Given this list of marker genes PSMD6, JAK1, PSMD7, IL6R, XIAP, SEM1, PSMB4, PSMD1, PSMA3, IL6ST, ARHGEF4, PSMB2, SRC, PSMD8, PSMC2, PSMB3, ACTB, CTNNB1, NFKB1, UBB, RPS27A, PSMD2, PSMD3, FARP2, PSMD11, UBC, PSMB6, IL6, PSMC3, PSMB1, STAT3, RELA, ACTC1, CTNND1 (catenin delta 1, NCBI Gene Id 82168), ACTA2, JAK2, CDC42, PSMB7, PSMA2 (NCBI Gene Id 5683), CDH1, PSMA5, PSMA1, JUP, VCL, CTSB, PSMC5, TYK2, PSMA7, UBA52, CDH11, HACE1, PSMC1, PSMA4, TIAM1, CTSL, PSMD13, BIRC2, CTSS, PSMA6, VAV2, CTNNA1, PSMD12 (proteasome 26S subunit, non-ATPase 12), CBLL1, RAC1, PSMC4, RNF19B, ACTA1, ADRM1, TRAF7, PSMD14, PSMC6, ACTG2, PSMB5 (proteasome 20S subunit beta 5), ACTG1, ELMO1, DOCK1, here is a description of the gene set: part of: Adherens junctions interactions Reactome Pathway: Activation of STAT3 by cadherin engagement studied in species Homo sapiens <p><b>The signal transducer and activator of transcription-3 (STAT3):</b></p><p>STAT3 is a latent cytoplasmic transcription factor, activated by receptor tyrosine kinases such as EGFR, or PDGFR, cytokine receptors such as the Interleukin-6 receptor family (IL6R or gp130 – also known as IL6ST), and non-receptor tyrosine kinases such as SRC. Activation entails phosphorylation of the critical tyrosine-705 residue (p-Y705) of STAT3 by the receptor itself or an associated Jak kinase, dimerization and translocation to the nucleus. The dimers subsequently bind specific DNA sequences to activate the transcription of specific genes involved in cell division and survival, while they downregulate the tumor suppressor p53, thus protecting tumor cells from apoptosis. Hyperactivation of STAT3 is present in a large number of cancers and has been reported to be required for tumour cell growth, survival, angiogenesis, metastasis and immune evasion, while a hyperactive form of Stat3 (Stat3C) is able to transform cultured cells.</p><p><b><u>Activation of Stat3 by cadherin engagement</u></b></p><p>Early results demonstrated that cell to cell contact, as occurs with confluence, or aggregation of cultured cells, leads to a dramatic increase in phosphorylation of STAT3 at the activating tyrosine-705 (p-Y705-STAT3), DNA binding and transcriptional activity, in both non-transformed mouse or rat fibroblasts or MCF-10A human breast cells, as well as in a series of four human breast cancer cell lines, and a number of human lung cancer cell lines.</p><p>It was later definitively demonstrated that STAT3 is activated by direct homophilic interactions of E-cadherin (CDH1) molecules of the opposing cells, even in the absence of direct cell to cell contact. This was shown by plating mouse epithelial HC11 cells onto surfaces coated with fragments encompassing the two outermost domains of CDH1. In fact, CDH1 engagement was shown to trigger a dramatic surge in total RAC1 and CDC42 protein levels and activity through inhibition of proteolytic degradation, and this was responsible for the STAT3 activation observed. It was further demonstrated that the increase in RAC1/Cdc42 activity leads to transcriptional upregulation of members of the IL6 family of cytokines through the transcription factor NFκB and activation of the common receptor, gp130 (IL6ST), leading to STAT3 activation, in an autocrine manner. STAT3 then dimerizes, migrates to the nucleus and activates transcription of genes involved in cell division, survival, proliferation and migration. In sharp contrast to STAT3, the activity of Erk1/2 (extracellular signal activated kinase, officially MAPK1/MAPK3) was unaffected by cell density, or cadherin engagement. Two mesenchymal cadherins, cadherin-11 (CDH11) and N-cadherin (CDH2) were also found to activate STAT3 in different cells, by similar mechanisms (Geletu, Arulanandam et al. 2013, reviewed in Geletu, Guy et al. 2013).</p>